The following is a description of a gene set: Human Gene Set: GOBP_EYELID_DEVELOPMENT_IN_CAMERA_TYPE_EYE The progression of the eyelid in a camera-type eye from its formation to the mature state. The eyelid is a membranous cover that helps protect and lubricate the eye. species: Homo sapiens, and this is the list of marker genes: HDAC1, TFAP2A, SOX11, EGFR, INHBA, SOS1, HDAC2, TWIST1, STRA6, OSR2, GRHL3, JUN, SRF, PRICKLE1